Given this list of marker genes Fgf10, Srpx, Col2a1, Snai2, Bcl2l10, Klf4, Tert, Tnf, Gfral, Wwox, Ppp1ca, Unc5b, Eya4, Ppp2r1b, Mcl1, Mapk7, Map2k5, Il1b, Eya2, Ripk1, Fgfr1, Dapk3, Jak3, Prdx2, Eya3, Bcl2, Agap2, Htra2, Gas1, Ret, Csf2, Gdnf, Ctnna1, Hspa1b, Ppp2r1a, Inhba, Gata1, Nrg1 (neuregulin 1), Sgk3, Cx3cl1, Eya1, Nf1, Fyn, Il7, Stradb, Tgfb2, here is a description of the gene set: Mouse Gene Set: GOBP_REGULATION_OF_EXTRINSIC_APOPTOTIC_SIGNALING_PATHWAY_IN_ABSENCE_OF_LIGAND Any process that modulates the frequency, rate or extent of extrinsic apoptotic signaling pathway in absence of ligand. species: Mus musculus